The following is a description of a gene set: from publication Yang F, Foekens JA, Yu J, Sieuwerts AM, Timmermans M, Klijn JG, Atkins D, Wang Y, Jiang Y (PMID 16261164) About 70-80% of breast cancers express estrogen receptor alpha (ER-alpha), and estrogens play important roles in the development and growth of hormone-dependent tumors. Together with lymph node metastasis, tumor size, and histological grade, ER status is considered as one of the prognostic factors in breast cancer, and an indicator for hormonal treatment. To investigate genes and pathways that are associated with ER status and epithelial cells in breast tumor, we applied laser capture microdissection (LCM) technology to capture epithelial tumor cells from 28 lymph node-negative breast tumor samples, in which 17 patients had ER-alpha+ tumors, and 11 patients have ER-alpha- tumors. Gene expression profiles were analysed on Affymetrix Hu133A GeneChip. Meanwhile, gene profiles using total RNA isolated from bulk tumors of the same 28 patients were also generated. In total, genes and genes with significant P-value and having significant differential expression between ER-alpha+ and ER-alpha- tumors were identified from the LCM data set and bulk tissue data set, respectively. A total of genes were found to be common in both data sets, while genes were unique to the LCM data set and genes were present only in the bulk tumor data set. Pathway analysis with the genes using Gene Ontology suggested that genes involved in endocytosis, ceramide generation, Ras/ERK/Ark cascade, and JAT-STAT pathways may play roles related to ER. The gene profiling with LCM-captured tumor cells provides a unique approach to study epithelial tumor cells and to gain an insight into signaling pathways associated with ER. Human Gene Set: YANG_BREAST_CANCER_ESR1_BULK_DN species: Homo sapiens Genes down-regulated in bulk samples from early primary breast tumors expressing ESR1 vs the ESR1 negative samples., and this is the list of marker genes: THEMIS2, LAD1, PFKP, PLAUR, DSE, CEBPB, KCNK5 (NCBI Gene Id 8645), TMEM123, TEX10, GTPBP4 (NCBI Gene Id 23560), NCK1, APBA2, ROPN1, TTK, MAP3K13, PLIN2, SIRPA, DEFB1, RIN3, GMPS, RGS16, LPIN1